The following is a description of a gene set: species: Mus musculus Formation of hard tissues that consist mainly of inorganic compounds, and also contain a small amounts of organic matrices that are believed to play important roles in their formation. Mouse Gene Set: GOBP_BIOMINERAL_TISSUE_DEVELOPMENT, and this is the list of marker genes: Tmem38b, Fgfr3, Col1a1, Atp2b2, Zmpste24, Pth1r (NCBI Gene Id 19228), Pkdcc, Eif2ak3, Gja1, Lncpint, Rogdi, Atg4b, Phospho1, Txlng, Adrb2, Herc1, Hif1a, Wnt6, Alox15, Atraid, Wdr72, Bmp4 (bone morphogenetic protein 4, NCBI Gene Id 12159), Fbn2, Tfip11, Acvr2b, Ddr2, Ifitm5, Minpp1, Comp, Isg15 (ISG15 ubiquitin-like modifier), Duox2, Enpp1, Aspn, Lgr4, Fgfr2, Rxrb, Bmp7, Ptk2b, Dnm3os, Pth, Oc90, Acvr1, Amtn, Gla, Bmp2k, Odam, Stim1, Notch1, Ppara, Tuft1 (NCBI Gene Id 22156), Icmt, Otol1, Rxra, Gpc3 (NCBI Gene Id 14734), Osr1, Mmp13, Rflna (NCBI Gene Id 73121), Slc20a1, Dicer1, Wnt10b, Smad3, Fam83h, Ccn1, S1pr1, Slc24a3, P2rx7, Smpd3, Ltf, Dspp, Amelx, Tgfb1, Notum, Mgp, Ccr1, Dmp1, Spp1, Ambn, Mtss1, Csf1r, Nos3, Hoxa3, Asgr2, Klk4, Itgb1bp1, Fam20c, Foxo1, Cd276, Bglap3, Tfap2a, Wnt11, Ibsp, Kl, Atp2b1, Hey2 (hairy/enhancer-of-split related with YRPW motif 2, NCBI Gene Id 30802), Msx2 (msh homeobox 2), Matn1, Slc4a2 (solute carrier family 4 (anion exchanger), member 2), Ercc2, Runx2 (NCBI Gene Id 12393), Bmpr1b, Adgrv1, Slc20a2, Tent5a, Cnnm4, Gata1, Hey1, Bglap, Ptn, Twist1, Clec3b, Cftr, Bmp6, Cer1, Fgfr1, Itgb6, Fosl2 (fos-like antigen 2), Ccdc154, Atf4, Asxl2, Ostn, Ank, Cst5, Ltbp3, Fzd9, Gcm2, Cyp27b1, Ift80, Acvr2a, Odaph, Mia3, Alox5, Osr2, Grem1, Axin2, Phex, Wnt4, Igf1, Tcirg1, Actn3, Alpl, Prickle1, Ano6, Enam, Fam20a, Hacd1, Col6a1, Bmpr2, Lox, Slc8a1, Otop1, Fgr, Bmpr1a, Fbxo5, Gas6, Sp7, Tmem119, Fgf23, Tcf7l2, Wls, Gpnmb, Klf10, Rspo2, Tbx1, Lep, Nell1, Nectin1, Mef2c, Rflnb, Dlk1, Sbds, Mepe, Nbr1, Snx10, Suv39h1, Ptgs2, Ccr1l1, Col1a2, Cebpb, Gpm6b, Sbno2, Trpm4, Fkrp, Bglap2, Pthlh, Sgms2, Ahsg, Vdr (vitamin D (1,25-dihydroxyvitamin D3) receptor), Srgn, Fbxl15, Ecm1, Sox9, Bmp2, Nfix, Nfe2, Bcor, Tspear